Given this list of marker genes Ldhb, Ldha, Park7, Per2, Htt, Ldhc, here is a description of the gene set: species: Mus musculus Mouse Gene Set: GOBP_LACTATE_BIOSYNTHETIC_PROCESS The chemical reactions and pathways resulting in the formation of lactate, the anion of lactic acid.